Given this list of marker genes Acox1, Acaa1a, Acox3, Crat, Acox2, Acoxl, Acaa1b, here is a description of the gene set: species: Mus musculus Mouse Gene Set: GOMF_ACYL_COA_OXIDASE_ACTIVITY Catalysis of the reaction: a 2,3-saturated acyl-CoA + O2 = a (2E)-enoyl-CoA + H2O2.